The following is a description of a gene set: part of: Incretin synthesis, secretion, and inactivation This event has been computationally inferred from an event that has been demonstrated in another species.<p>The inference is based on the homology mapping from PANTHER. Briefly, reactions for which all involved PhysicalEntities (in input, output and catalyst) have a mapped orthologue/paralogue (for complexes at least 75% of components must have a mapping) are inferred to the other species. species: Mus musculus electronically inferred by orthology from the curated human pathway Reactome Pathway: Synthesis, secretion, and inactivation of Glucagon-like Peptide-1 (GLP-1), and this is the list of marker genes: Gnb3, Gnat3, Grp, Gcg, Dpp4, Lep, Ffar1